Given this list of marker genes RPS6KA2, SRRM4, BAP1, CCNB1, VSX1, ASCL1, SPTBN4, BFSP1, SMIM45, SCLT1, SOX18, FOXA1, ERCC2, PLA2G10 (NCBI Gene Id 8399), ROPN1, GLDN, MECP2, PPARG, RAC1, AKR1B1, KCNB1, PLA2G3, GHRHR, CCL19, MTCH1, RAB24, MYOC, GALNT3, TUBB8, FAM20C, FUT6 (fucosyltransferase 6), KLF2, CATSPERZ, BNC1, ID2, IRX5, XBP1, TFCP2L1, CNTN2, AXL, CDC25B, ANG, G6PD, ANGPTL8, PTBP3, HOXA5, RAC2, CNTNAP2, CATSPER2, PTH1R, HES1, EDNRA, LGI4, SLC26A3, C2CD6, IHH (Indian hedgehog signaling molecule), BHLHA15, DAZL, TUT4, DIAPH3, DLD, TDRKH, KCNIP2 (potassium voltage-gated channel interacting protein 2), CATSPER3, FZD5, EPHA8, CCL21, BSPH1, REC8, DMC1, FLVCR1, ROPN1L (rhophilin associated tail protein 1 like), BRD1, TBX6, MAEA, B4GALT5, BRCA2, EDN1, CBFB, SPG21, RET, FEM1B, FBXO41, SOX8, PLD6, HEATR3, SIX3, KCNE1, CTNNB1, CATSPER4 (NCBI Gene Id 378807), EPAS1, GATA2, RAC3, NR4A2, ACTL6B, SEMG2, TMPRSS12, ZAR1L, CATSPERD (NCBI Gene Id 257062), FAM210B, BTK, IQCF1, ELSPBP1, RXFP2, CCDC39, MOS, ABHD2, PGR, SLC26A6, TGFB1, H3-3A, GATA3, TDRD7, ZBTB7A, GPAT4, TRIM58, FOXO3, SLFN14, TCP11, TCP11X1, REN, KCNQ3, SLC22A14, L3MBTL3, EDNRB, APP, PCSK4, BFSP2, FOXJ1, FARP2, WASHC5, NPR2, EPB42, RB1, TMIGD1, RHEX, CABYR, VEGFA, EPO, EFCAB9, TDRD5, SHB, FGFR1, TDRD1, KDR, SCARF1, NPPC, CEBPA, FBXO5, LSM14B, LRRK2, P2RX5, WEE2, CX3CL1, GDF11, RFX3, TAL1 (NCBI Gene Id 6886), TMEM79, IL21, CLN5, NGF, C1QL1, DEFB1, HES5 (NCBI Gene Id 388585), B4GALT6, NKX6-1, TUT7, RUNX2, ANKS1A, HOXB13, TUSC2, YTHDF2, BCL11A, PDE3A, LCN6, EREG, BCL2 (BCL2 apoptosis regulator), PAEP, AGRN, FEV, AURKA (aurora kinase A), TDRD6, HDAC6, CDKN1C, LHX6, SPINK1, IER3IP1, CLEC7A, PICK1, KDM1A, CFTR, ADGRB3, KIF14, ZAR1, MAP3K13, IL15, TRIP13, ADAM7, ROPN1B, NTN4 (NCBI Gene Id 95736), NEMP1, TCP11X2, HBZ, RND1, C1QA, H3-3B, CATSPERE, GBA1, NRCAM, PRKACA, HIF1A, WDR77, CCR6, PPP2R1A, SOX10, OOSP2, SEMG1, SIRT2, C3, here is a description of the gene set: The cellular developmental process, independent of morphogenetic (shape) change, that is required for a specific cell to attain its fully functional state. studied in species Homo sapiens Human Gene Set: GOBP_CELL_MATURATION